The following is a description of a gene set: studied in species Homo sapiens Human Gene Set: HP_COLON_CANCER Colon cancer, and this is the list of marker genes: BUB1B, MINPP1, BRCA1 (BRCA1 DNA repair associated), MUTYH, BUB1, PMS1, GREM1, NTHL1, C1S, RABL3, MSH2, PALLD, MDM2, CDKN2A, NF1, PMS2, MBD4, SMAD7, PALB2, BMPR1A, APC, CHEK2, MLH1, HABP2, EPCAM, FOXE1, BUB3, SMAD4, KRAS, PIK3CA, MSH3, AXIN2, TP53, MSH6, BRCA2, FLCN, CEP57, RPS19, TGFBR2, TRIP13